The following is a description of a gene set: Mouse Gene Set: GOBP_VITAMIN_A_METABOLIC_PROCESS The chemical reactions and pathways involving any of the vitamin A compounds, retinol, retinal (retinaldehyde) and retinoic acid, all of which are derivatives of beta-carotene. species: Mus musculus, and this is the list of marker genes: Dgat1, Rbp1, Lipa, Lrat, Isx